Given this list of marker genes LMNB1 (lamin B1), EBP, HIKESHI, MTMR2, SPTBN4, TIMM8A, ARHGEF2, PSAP (prosaposin), ERCC4, ERCC8, NDRG1, SH3TC2, ERCC6, RIPOR2, GALC, MOGS, NEFL, EDNRB, OTOF, SOX10, NMNAT1, KARS1, MYH3, OPA1, CYP27A1, GJC2, HYCC1, DIAPH3, here is a description of the gene set: Abnormal auditory evoked potentials studied in species Homo sapiens An abnormality of the auditory evoked potentials, which are used to trace the signal generated by a sound, from the cochlear nerve, through the lateral lemniscus, to the medial geniculate nucleus, and to the cortex. Human Gene Set: HP_ABNORMAL_AUDITORY_EVOKED_POTENTIALS